The following is a description of a gene set: Telangiectasia of the mucosa, the mucous membranes which are involved in absorption and secretion that line cavities that are exposed to the external environment and internal organs. Mucosal telangiectasiae Human Gene Set: HP_MUCOSAL_TELANGIECTASIAE studied in species Homo sapiens, and this is the list of marker genes: ERCC3, KLLN, GLA, ERCC2, SASH1, DDB2, PEX6, SETX, LIG1, ACVRL1, ATM, CAV1, PIK3CA, GNAQ, XPC, MASP1, NAGA, IRF5, SMAD4 (SMAD family member 4), CTC1 (CST telomere replication complex component 1), ERCC4, CCR6, HLA-DRB1, NBN, LBR, CCN2, ERCC5, KIAA0319L, PCNA, SDHC, ENG, RNF168, PTEN, USF3, SEC23B, XPA, CTSA, GDF2, AKT1, SDHB, SDHD